The following is a description of a gene set: Human Gene Set: BANDRES_RESPONSE_TO_CARMUSTIN_MGMT_24HR_UP from publication Bandres E, Andion E, Escalada A, Honorato B, Catalan V, Cubedo E, Cordeu L, Garcia F, Zarate R, Zabalegui N, Garcia-Foncillas J (PMID 15980968) studied in species Homo sapiens Genes up-regulated in T98G cells (glioma, express MGMT) by carmustine at 24 h. Chemotherapy with the alkylating agent BCNU (1,3-bis (2-chloroethyl)-1-nitrosourea) is the most commonly used chemotherapeutic agent for gliomas. However, the usefulness of this agent is limited because tumor cell resistance to BCNU is frequently found in clinical brain tumor therapy. The O6-methylguanine-DNA methyltransferase protein (MGMT) reverses alkylation at the O6 position of guanine and we have reported the role of MGMT in the response of brain tumors to alkylating agents. However, the different mechanisms underlying the patterns related to MGMT remain unclear. To better understand the molecular mechanism by which BCNU exerts its effect in glioma cell lines according MGMT expression, we used microarray technology to interrogate 3800 known genes and determine the gene expression profiles altered by BCNU treatment. Our results showed that treatment with BCNU alters the expression of a diverse group of genes in a time-dependent manner. A subset of gene changes was found common in both glioma cell lines and other subset is specific of each cell line. After 24 h of BCNU treatment, up-regulation of transcription factors involved in the nucleation of both RNA polymerase II and III transcription initiation complexes was reported. Interestingly, BCNU promoted the expression of actin-dependent regulators of chromatin. Similar effects were found with higher BCNU doses in MGMT+ cell line showing a similar mechanism that in MGMT-deficient cell with standard doses. Our data suggest that human glioma cell lines treated with BCNU, independently of MGMT expression, show changes in the expression of cell cycle and survival-related genes interfering the transcription mechanisms and the chromatin regulation., and this is the list of marker genes: GDI1, FNTA, SNAPC3, ECM2, SNAPC1, SMPD2, SNRPB2, TMBIM6, SMARCD1